Given this list of marker genes WRAP53, STN1, TEN1, ACD, TINF2, RUVBL2, RUVBL1, TERF2IP, DKC1, TERC, TERF2, NOP10, CTC1, TERT, NHP2, GAR1, POT1, RTEL1, TERF1, here is a description of the gene set: studied in species Homo sapiens Telomere elongation. Pathway ID: N01477. Pathway type: Reference. Pathway class: nt06510 Telomere length regulation. Human Gene Set: KEGG_MEDICUS_REFERENCE_TELOMERE_ELONGATION Pathway Definition from KEGG: RTEL1+RAP1+TRF2+TIN2+TRF1+POT1+ACD == telomerase -> Shelterin == CTC1+STN1+TEN1